Given this list of marker genes Acvr1b, Sostdc1, Bmpr1b, Tgfbr2, Acvr2b, Tgfbr1, Hjv, Bmpr1a, Bmpr2, Acvr1c, Acvrl1, Acvr2a, Amhr2, Acvr1, here is a description of the gene set: Mouse Gene Set: GOMF_BMP_RECEPTOR_ACTIVITY Combining with a member of the bone morphogenetic protein (BMP) family, and transmitting a signal across the plasma membrane to initiate a change in cell activity. species: Mus musculus